Given this list of marker genes MGAT5, PPIA, OSTC, HLA-H, ATP1B1, NFE2L2, IGLC6, IFNA8, RPS27, CAV1, IFNA14 (NCBI Gene Id 3448), ST3GAL1, IGLV1-40, IGHV3-30, FXYD3, ATP1A1, CRBN, VEGFA, KDM1A, SYK, PTGES3, IGLV3-27 (NCBI Gene Id 28791), SH3KBP1, GPC1, MGAT4B, CRB3 (crumbs cell polarity complex component 3), RPS18, REST, RPS4Y1, ST3GAL4, GOLGA7, IFNGR2, TBK1, PKLR, SOS1, CTSL, GEMIN7, ANO2, GPC2, IL17F, ZDHHC9, IKBKE, AP2A2, MTA3, GALNT1, SRPK1, IFNA6, GRB2, IRF3, HNRNPA1, MASP2, GEMIN4, DDOST, IFNA21, IFNA5, TLR9, NUP160, MBD3, ZDHHC3, IMPDH1, RBBP4, TUFM, IGLV3-21, ATP1B3, BCL2L1 (NCBI Gene Id 598), IGLV1-47, RBX1, ST3GAL3, MTA2, IFNA10, VPS45, 7SL RNA (ENSG00000222639), AKT1, RNF135, RUNX1, ACE2, VPS33A, SARS coronavirus, complete genome, IFNAR1, PARP9 (NCBI Gene Id 83666), AAAS (aladin WD repeat nucleoporin), IFNGR1, LARP1, IGHV2-5, STING1 (NCBI Gene Id 340061), RPS27A, MAGT1, RPSA, PARP14, 7SL RNA (ENSG00000222619), IRAK2, TLR1, IGKV1-33, GPC6, DAD1, SDC2, NUP37, MAVS, GANAB, RIPK3, EDEM2, IGLV2-11, AP2A1, NS5B, ST3GAL2, MGAT2, 3b, HSP90AA1, IGHV2-70, PYCARD, EP300, NUP85, IL6R, GPC4, SAR1B, YWHAQ, ANO10, FXYD4, PIK3C3, PPIG, ANO9, PIK3R4, ANO1, CSNK1A1, STAT1, VAV1, 8, STT3B, GEMIN5, CD79B (NCBI Gene Id 974), RPS26, TYK2, IGKV2D-28, UBA52, NUP93, IGHV3-23, IGLV, BRD4, SNRPD1, YWHAG, RPS24, VPS11, MGAT1, 1a, TRAF3, ZDHHC2, PALS1, UBE2V1, NFKBIA, 18S rRNA, ISCU (iron-sulfur cluster assembly enzyme), IGKV1-17, B2M, KEAP1, HSPG2, ANO7, VPS18, IGLV2-23, MAN2A1, FAU, NLRP3, IGKV1-39, UBE2N, G3BP1, NUP133, KPNB1, NUP188, IGHV4-34, VPS16, JAK2, SNRPF, YWHAZ, HLA-G (NCBI Gene Id 3135), NUP42, pp1a, ARID4B, CYSLTR1, RPS6, RPS9, IL17RA, HLA-F, SEC24A, SFN, NLRP12, BTK, IGKV2D-40, NUP153, RPS25, NUP43, PPIB, TLR7, HLA-B, IFNAR2, IGKV4-1, CHMP3, CREBBP, MASP1, PDCD1, IGLC1, MGAT4A, HLA-E, COMT, HAVCR1, ROCK1, CUL3, GEMIN6, NRP1, 8b, IGHV1-2, SRPK2, YWHAB, IGHV3-33, IGHV4-39, PCBP2, G3BP2, SUDS3, TUBB, TLR8, ST6GAL1, NPIPB3, RPS16, RPS20, DDX5, SNRPD3, SUMO1, IGKV1-16, RPS15, PARP4, PHF21A, RPS14, VPS39, IGLV3-1, IGKV1D-39, DDX20, RPS12, ATP1A4, IKBKG, CHUK, OST4, MAP3K7, ATP1B2, FKBP4, SDC4, TLR2, NDC1, RIPK2, NR3C1, AP2B1, NCK1, S, NUP98, PSMC6, FXYD6, PRMT1, MGAT4C, 3a, IGKV1D-16, SAP30, SERPINE1, SNRPD2, FNTA, TOMM70, IFNB1, EEF1A1, SEC23A, GATAD2B, CHMP4C, IGLV6-57, RCOR1 (NCBI Gene Id 23186), GEMIN2, NPM1, IFNA1, IGKV2D-30, 6, CHMP4B, IRAK1, CHD3, ANO3, RPS8, IGLV1-44, MAN1B1, IGKV1D-12, HLA-A, NUP54, RPS10, RIPK1, HMG20B, PTPN6, SAP18, RB1, IGLV3-25, TAB3, RPS5, FUT8, RPS15A, SEC24B, NUP107, IGLV7-43, CD79A, RPN1, MTA1, IGHV3-48, ZDHHC5, CHMP7 (NCBI Gene Id 91782), CANX, FKBP1A, ANO4, BECN1, RPS4X (NCBI Gene Id 6191), SIGMAR1, PRKCSH, SDC1, TRIM4, IGHD, NOD2, HLA-C, IL17A, S1PR1, YWHAH, IGHV3-7, AP2M1, RPS19, PTPN11, SMAD4, IGHV4-59, VCP, M, PDPK1, IGKV3-11, GATAD2A, NUP35, CHMP2B (NCBI Gene Id 7877), RPS27L, TUSC3, STT3A, NUP50, PARP16, KPNA2, UBC, RPS4Y2, RPS2, IGKV5-2, RPS3A (NCBI Gene Id 6189), MOGS, IFNA2 (interferon alpha 2), JAK3, IGHV3-11, VPS33B, RPS28, ZDHHC11, FURIN, GSK3A, SAP30L, CHD4, IGLV2-8, ST6GALNAC4, RPS21, HSP90AB1, FXYD1, IGKV2-28, IFIH1, NUP58, CASP1 (NCBI Gene Id 834), IGLC7, JAK1, VPS41, PARP6, AKT2, NUP214, IGHV, RPS11, GEMIN8, IGKV1-12, ATP1A2, BRMS1, ZDHHC8, HDAC2, RPN2, N, IGHV3-9, IGHV1-46, PLCG2, CNBP, SMN1, IGKV3-20, ITGB1, TPR, NMI, SNRPE, ST6GALNAC3 (ST6 N-acetylgalactosaminide alpha-2,6-sialyltransferase 3), ZDHHC20, IMPDH2, CHMP4A, IGKV1D-33, ANO8, IGHV1-69, SMAD3, SP1, FXYD2, TMPRSS2, SEC13, NUP88, RPS13, POM121, IL1R1, RPS7, SEH1L, UBB, ST6GALNAC2, ISG15, SNRPB, PARP8, TKFC, IRF7, RANBP2, NUP155, ROCK2, NUP210, UVRAG, IKBKB, RELA, IGKC, BLNK, NUP205, RBBP7, AKT3, rep, ARID4A, IGKV2-29, MAP1LC3B, RIGI, SEC24C, IGLC2, IGLV2-14, PATJ, ANO6, ZCRB1, ATG14, CHMP6, TRAF6 (TNF receptor associated factor 6), 7a, POM121C, NOD1, ZBP1, SDC3, SFTPD, TMEM258, NFKB1, RPS23, IFNA17 (NCBI Gene Id 3451), RPS17, AP2S1, IGHV7-81, MBL2, UBE2I (ubiquitin conjugating enzyme E2 I), SIKE1, ATP1A3 (ATPase Na+/K+ transporting subunit alpha 3), PPIH, HDAC1, IGKV2-30, GPC5, SEC24D, IGKV1-5, BST2, IGHV3-53, NUP62, ITCH, FXYD7, IGKV3-15, AGRN, IGLV3-19, TAB2, IGKV3D-20, IGLV1-51, RCAN3, CHMP2A, E, TAB1, RPS29, IFNA7, IGHM, YWHAE, ANO5, PARP10, IL17RC, VHL (NCBI Gene Id 8056), IGLC3, RAE1, TRIM25, TJP1, GJA1, STAT2, IFNA16, RPS3, GSK3B, IGHV3-13, 9b, SNRPG (small nuclear ribonucleoprotein polypeptide G), FNTB, ITGA4, IFNA4, GPC3, here is a description of the gene set: part of: Viral Infection Pathways Reactome Pathway: SARS-CoV Infections studied in species Homo sapiens Coronaviruses (CoVs) are large, enveloped, positive strand RNA viruses that can be classified into four genera: alpha, beta, delta, and gamma. Coronaviruses are ecologically diverse, infecting animals including camels, cattle, cats, and bats, with the greatest variety seen in bats, suggesting that bats are the reservoirs for many of these viruses. Rarely, A and B lineage beta coronaviruses of non-human origin can infect people and then spread directly between people. Four human coronaviruses (HCoVs), HCoV 229E, NL63, OC43, and HKU1, are endemic globally and account for 10% to 30% of upper respiratory tract infections in adults, typically presenting as common colds (van der Hoek 2007). However, in the 21st century, three highly pathogenic HCoVs - severe acute respiratory syndrome coronavirus (SARS-CoV-1) in 2003, Middle East Respiratory Syndrome coronavirus (MERS CoV) in 2012, and SARS-CoV-2 in 2019 - emerged from animal reservoirs to cause global epidemics with alarming morbidity and mortality (De Wit et al. 2016; Fung & Liu 2019; Marra et al. 2003; Paules et al. 2020).<br><br>During the 2003 outbreak of SARS-CoV-1, 8,098 people worldwide became sick. Of these, 774 died. In the United States, only eight people had laboratory evidence of SARS-CoV-1 infection. All of these people had traveled to other parts of the world where the disease was spreading. Community spread was not observed in the United States (De Wit et al. 2016; WHO - SARS). A second human coronavirus, MERS-CoV, first observed in 2012, has been identified in 2,494 patients with respiratory distress of whom 858 have died. Human-to-human transmission of the virus appears to be limited (De Wit et al. 2016; WHO – MERS). <br><br>In December 2019, yet another pathogenic HCoV, 2019 novel coronavirus (2019 nCoV), was recognized, initially in Wuhan, China. The World Health Organization has named the disease caused by the 2019 novel coronavirus COronaVIrus Disease 2019, or COVID-19. The disease has also been referred to as 2019 novel coronavirus or 2019 nCoV. <br><br>SARS-CoV-1 and SARS-CoV-2 viral infection pathways are annotated in this section, as are drugs that potentially modulate the infection processes. Many of the steps of SARS-CoV-1 infection have been characterized experimentally in the past 15 years (Fung & Liu 2019; Masters 2006), and this experimental work has allowed the annotation here of the infection process and interactions with host proteins in molecular detail. Less comparable data is yet available for SARS-CoV-2 infection, but the similarity in the genomes and predicted proteomes of the two viruses allows the inference of a detailed infection pathway for SARS-CoV-2 that has been manually annotated as well with experimental results published in the first half of 2020.